Given this list of marker genes CSMD2, ZNF721, ACTN1, IPO7, DGKH, CTSC, FAM76A, EREG, HIPK2, ENDOV, IVL, IL10, CASC3, CYRIB, MNAT1, VPS53, SP1, ZNF705EP, ZNF705D, CRISPLD1, ANKRD13A, KLHL5, BTRC, ASCL4, ZNF543, SERTM1, MRPS35, CHL1, GRSF1, C1orf115, ZNF705A, TPR, CCDC178, FCHSD2, FAM120C, MAEA, RBM12, ZBTB20, MYO6, ZNF516, CDADC1, XIRP2, FST, PDZK1, PLP1, FAM20B, PDE1C, LTBP1, HMGB3, PLEKHA2, ERGIC1, ANAPC10, RHOBTB3, FER1L6, CHST7, ACAN, PIK3C3, HTR4, MIB1, AMIGO1, PAG1, RAB10, EOLA1 (NCBI Gene Id 91966), GPC4 (glypican 4), PPP1R9A, ZDHHC3, APBA1, DCAF1, INO80D, KCMF1, RABEP1 (rabaptin, RAB GTPase binding effector protein 1), TBC1D7, PCGF6, HECW2, NR2F2, PTPRT, ZNF684, ZBED10P, PCDH11Y, MAK16, WEE2, SLC26A11, NSD1, SREK1, ETNK1, PACRG, RGS1, PLEKHA3, BEND6, RTF1, WIPF2, NR2F1, TOM1L2, USP48, ADAMTS9, GPR182, C15orf48, ELAPOR2, SSTR3 (NCBI Gene Id 6753), F5, ARID1B (AT-rich interaction domain 1B), CYTH1, PLEKHG4B, JUND, CNOT2, FAM9A, CPD, IFT122, CCSER1, RDX, YTHDF2, MYO5B, SORBS3, TACR1, CRX, PNP, GALNT6, FAM221B, PCDH15, NCKAP5, CAMK2G, ST8SIA2, TM9SF4, CDH20, YAP1, AMMECR1, ABI2, SLC37A3, ZFAND5, ACTRT3, TPT1, SEC22C (NCBI Gene Id 9117), TSR2, SLC9A6, FMO5, DENND4A, TMEM263, RABL3, CYP4V2, TMEM161B, MAGEB18, CNOT6L, TMEM209, COL11A2, TXLNB, SLC24A4, SERTAD2 (NCBI Gene Id 9792), BCL2L13, TCAF1, IFNAR2, ZBTB43, UTP15, DLG2 (NCBI Gene Id 283225), GLRA1, GPM6B, ENY2, CASK, BHLHE40, CENPBD1P, PAPSS2, DOCK5, SLC44A1, REP15, MTCL2, UBR7, RASGRF2, NIBAN1, PCSK2, ZNF704, KIRREL2, MAP10, CLEC16A (NCBI Gene Id 441746), AMER1, ASB11, ZNF708, TNRC6B, INPP4B, ZNF766, GRIA1, ABLIM3, TMEM178B, PLEKHO2, FBXL2, SART1, S100PBP, ZNF106, GALNT1, WDR3 (NCBI Gene Id 10885), POLR3A, MYCBP, TACC1, PRMT3, ARL3, EMC2, MYSM1, WDR81, PDX1, here is a description of the gene set: Human Gene Set: MIR1236_3P studied in species Homo sapiens Genes predicted to be targets of miRBase v22 microRNA hsa-miR-1236-3p in miRDB v6.0 with MirTarget v4 prediction scores > 80 (high confidence targets). from publication Chen Y, Wang X (PMID 31504780)